Given this list of marker genes DNAH7, DCTN1, DNAH5, DNAH2 (dynein axonemal heavy chain 2), DNAI2, DCTN2, DNAL1, ACTR1B, DCTN5, DNAH11 (NCBI Gene Id 8719), ACTR1A, DNAH8, DNAL4, DNAH17, DNAI1, DCTN3, DNAH6, DNALI1 (dynein axonemal light intermediate chain 1), SOD1, DCTN6, DNAH9, DNAH12, ACTR10, DCTN4, DNAH1, DNAH3, DNAH10, here is a description of the gene set: Mutation-caused aberrant SOD1 to retrograde axonal transport. Pathway ID: N01160. Pathway type: Variant. Pathway class: nt06464 Amyotrophic lateral sclerosis. Human Gene Set: KEGG_MEDICUS_VARIANT_MUTATION_CAUSED_ABERRANT_SOD1_TO_RETROGRADE_AXONAL_TRANSPORT Pathway Definition from KEGG: SOD1* -| (DCTN+DNAH+DNAI+DNALI1+DNAL) studied in species Homo sapiens